The following is a description of a gene set: Human Gene Set: MIR130B_5P from publication Chen Y, Wang X (PMID 31504780) studied in species Homo sapiens Genes predicted to be targets of miRBase v22 microRNA hsa-miR-130b-5p in miRDB v6.0 with MirTarget v4 prediction scores > 80 (high confidence targets)., and this is the list of marker genes: SLK (NCBI Gene Id 9748), EPHA7, RAB29, ITPRIP, NR2F2, CNOT1 (CCR4-NOT transcription complex subunit 1), RALGPS2 (NCBI Gene Id 55103), PCDH17, TNFRSF11B, PAK2, ERP27 (endoplasmic reticulum protein 27), TBC1D8B, ARID3A, SOSTDC1, ZNF430, ASPH, EAF1, CHRDL1, ONECUT2, DIABLO, NLGN4X, NDFIP2, CNKSR2, RB1CC1, PTX3, CDK12, MAFG, PCDH20, PRDM6, CCDC34, UBE2D2, ADAMTS3, CGNL1, PAPOLG, POU3F2, TRPS1, TRIM71, MYLK3, ACSM2A, TBL1XR1, BTN3A2, ANKH, SMARCA1, ARID5B, ZFX, ZNF326, LRRC66, AK2, TSC22D1, FBXO11, GATA6, GUCY1A2, SOX1, RBM20, NPTX1, XPO4 (exportin 4), ACOT8, ZNF460, CD2AP, TMEM19, CPEB3, ADAM10, KCNB1, PCSK6, DPP10 (NCBI Gene Id 57628), RSBN1, OLFM1, UBE2V2, TTC14, DENND5A, MCFD2, IGFBP2, CASK, PTBP1, TSPAN2, NRXN1, ACSM2B, GRAMD1B, SAMD4A, HAND1, SLC1A1, ZNF469, OGA, UNC5D, SDHAF2, WWTR1, SPTY2D1, RPRD2, KIAA1549L, CD300LD-AS1, PRKG1, C8orf34, DIO2, KLHL14, MEF2C, ATP8A2, TFCP2, GRIA1, RAB11FIP2, CRY2 (cryptochrome circadian regulator 2), ZSCAN12, IL33, PPP4R2, ABLIM1, STAP1, MEF2A, DYNLT5, H2AX, DAAM1, SH3BGRL2, SOX9, STIMATE, LZTFL1, TLCD4-RWDD3, HOXA3, ZBTB10, ILDR2, MEI4, RORA, SLC5A12, SNRPC, PPP1R10, AKAP6, NAV2, ACVR1C, SAMD8, IRAK1BP1, DPH3, TCF7L1, KCNK6, CHMP7, ATP11C, PDCD6IP, LENG8, ASH1L, AP1G1, SIX4, CHIC1, LPP, ZBTB20, ECHDC1, CREG2, RABEP1, NOVA1, FREM2, WBP1, ZNF721, TET2, UQCRB, PDHX, KIAA0513, CWC15, SPP1, CORO2A, LPIN2, ENDOU, CLIC5, SLC26A7, SLC26A4, RNF217 (NCBI Gene Id 154214), PLP1 (NCBI Gene Id 5354), MAPK9, TAFA5, ARHGEF6, CSRNP3, ZSCAN26, MTCL3, SGIP1, AUTS2, MSI2, ARG1, RBFOX2, EBF4, ADRA1A, SSMEM1, PTER, ZNF704, ATXN7, PURA, C11orf54, CRISPLD1, TRIM65, SLC17A6, PDE1C, IGF1, PLXNA4, ENSG00000187186, UTRN, HRH1, ZNF827, FMN1, SH3RF1 (SH3 domain containing ring finger 1), SYAP1, PCNX1, CPEB4, RHOA, CLDN19